Given this list of marker genes IL18R1, GNA12, RENBP, IL1B, SDC4, MAP3K1, ITGB5, SLC26A2, AK4, IFIT1, DSC2, DNTTIP2, STAT5A, APBB3, OLFML2B, TUT4, CPQ, SQSTM1, CDH5 (cadherin 5), PLIN2, FYN (FYN proto-oncogene, Src family tyrosine kinase), ATP1B1, KDM6A, MTSS1, ASMTL, ACVR1, CPM, ADCY9, CRK, STMN1, SERPINB2, NID1, SDC2, TUG1, ANKLE2 (NCBI Gene Id 23141), TNIP1, SLC7A8, AMPD3, EIF4B, WWP1, TRA2A, TMPRSS2, AKR1B1, C3AR1, TSPAN4, PES1, RPS6KA2, PLAGL2, FOLR2, BTG1, USF2, NISCH, THAP12, TSPYL5, HOMER3, CD47, RIN2, NRP1, CITED2, HGF, CTSK, LIG4, MPP1, TIMP1, CTSZ (cathepsin Z), MITF, TNFRSF14, MAP4K4, F13A1, ZKSCAN1, IGF1, TRAF1, KCNJ15, CCL1, YTHDF3, ZC3H15, TIMP2, IKZF1, RNASE1, TNFRSF4, ZHX2, PANX1, MTF1, DUSP14, IL6, SLA, DAPK1, CCL5, TLR2, PIM2, P2RX4, PLD3, HEXA, TNF, IL7R, TP53BP2, ARHGEF2, GYPC, ATM, GOSR2, GPR107, CDC42EP3, BCAR3, AGFG1, KANK1, PPP3CB, SERTAD2, UTRN, CXCL11, IRF8, LSR, STK10, PTGER4, BLZF1, RBMXL2, HSD17B4, NCOR2, TNFSF8, TECR, MAP2K3, RPL13P5, ZNF22, FAS, GEM, PTP4A1, MGMT, HNRNPA0, BID, RRAD, SRSF6, PIP, CD99, PIK3CA, WDR1, ATP8A1, ADH5, DNAJA2, STAB1, PFDN4, IL2RA, NUCB2, EHD1, NLRP3, BATF, ZNF3, PTX3, CCL18, FN1, CCL20, VPS4B, TNFRSF21, SEC23B, CLEC11A, SATB1, DENND5A, DYRK3, ZNF253, AP1B1, LAMC1, THBS1, CPVL, EREG, BCL2A1, PLTP, CTSF, WTAP, PDPN, MAP3K8, IL15RA, BCAT1, ATRN (attractin), STK17A, KMO, ZNF200, HNMT, MARK3, TRIP10, RRS1, CYRIA, OAZ2, CXCL3, PTPRJ, UTP3, CELSR1, ADORA2A, ADD3, CXCL2, OLFML2A, CHST2, ADAM20, GADD45B, CAMKK2, FBLN5, SELENOP, ICAM1, CCT6A, EIF2S3, ABR, GPNMB, here is a description of the gene set: Germinal centers (GCs) are clusters of activated B cells built on stromal cells known as follicular dendritic cells (FDCs). In the Peyer’s patches (PPs), GCs are chronically induced by bacteria and are the major sites for generation of gut IgA immune responses. Whether FDCs directly contribute to the IgA production in PP GCs is unknown. To investigate the role FDCs in gut immune system, we examined comprehensive gene profiles of FDCs purified from PPs or perypheral lymph nodes (pLNs) with or without immunization. We also tried to reconstitute the PP FDC signature in vitro by pulsed or continuous stimulation of pLN FDCs through TLRs, RARs or simultaneously through TLRs and RARs. studied in species Homo sapiens Genes down-regulated in the in vitro follicular dendritic cells from peripheral lymph nodes: non-stimulated versus tretinoin and Pam2CSK4 (96h). from publication Suzuki K, Maruya M, Kawamoto S, Sitnik K, Kitamura H, Agace WW, Fagarasan S (PMID 20643338) Human Gene Set: GSE19401_UNSTIM_VS_RETINOIC_ACID_AND_PAM2CSK4_STIM_FOLLICULAR_DC_DN